The following is a description of a gene set: species: Homo sapiens Catalysis of the movement of lipids from the exoplasmic to the cytosolic leaflet of a membrane, using energy from the hydrolysis of ATP. Human Gene Set: GOMF_FLIPPASE_ACTIVITY, and this is the list of marker genes: ATP10A, ABCA4, ATP10D, ATP10B, ATP8B1, ATP11C (ATPase phospholipid transporting 11C), ATP8A2, ABCA3, ABCB1, MFSD2A, TMEM30B, ATP11A, TMEM30A, ATP8A1, ATP8B2